The following is a description of a gene set: The activation signaling of transcription factor nuclear factor-kB (NF-kB) plays central role for immune system. One of key kinase mediating this pathway is TAK1 in adaptive and innate immunity. However, role of TAK1 in B cell receptor signaling is still unclear. To know effects of TAK1-deletion on the gene expression induced by anti-IgM, we performed the time course analysis in comparison of wild type with TAK1-deleted splenic B cells. from publication Shinohara H, Behar M, Inoue K, Hiroshima M, Yasuda T, Nagashima T, Kimura S, Sanjo H, Maeda S, Yumoto N, Ki S, Akira S, Sako Y, Hoffmann A, Kurosaki T, Okada-Hatakeyama M (PMID 24833394) Human Gene Set: GSE41176_UNSTIM_VS_ANTI_IGM_STIM_TAK1_KO_BCELL_3H_UP studied in species Homo sapiens Genes up-regulated in B lymphocytes with MAP3K7 knockout: untreated versus anti IgM for 3h., and this is the list of marker genes: RAMP2, TRIM11, TMEM238, CDHR1, GGNBP2, CARM1, FGF17, DCAF4, ZFP41, MRPL46, ELMOD3, RERG, PSMG1, LINC00612 (NCBI Gene Id 442755), PYCR3, ZNF629, BORCS7, ECH1, RAB3GAP1, PGAP4, DKK1, LYZL1, STOX1, ADORA2A (adenosine A2a receptor), MISP, SMIM20, ATP7B, TBC1D16, LRRIQ4, HCRTR1, POLR2E, KLHL23, INSYN1, CYTH3, SLX9, CEP131, SLC22A9, RPL35, COMMD7, GLIS3, FBXL14, SLC15A4, MBOAT4, SLC4A10, IL24, CCDC146, EHMT2, CFD, WIF1, KY, DDI1, SH2D5, SNRNP27, XPNPEP3, PRR14L, CLK3, C1QTNF12, ZIC5, FANCD2OS, CCDC73, DUS2, SEMA3D, NUDT18, KRTDAP, OPALIN, KCTD2, SMCO4, AEBP1, KPTN, CYP17A1, TRMT44, SAP30L, MGAT3, SRRD, LAMTOR4, ALKBH3, INSRR, ADAM22, PGP, SLC35D3, SLC25A6, DNALI1, BOLA3, HOXC8, SLC26A1, IFT140, ELOF1, CLTB, DOCK6, RAD9B, ALDH3B1, ARRDC4, TNNT3, TTBK2, GPS2, CGN, ASCC1, GRIK2, SLC25A14, TSPAN1 (tetraspanin 1), POM121L12, CEND1, DLK1, KLHL36, GPRIN2, ELAVL3, SH2D3C, TNRC6A, KCNC4, FXYD5, MED12L, EDA, SAP18, TMEM39B, LMOD3, CPLANE1, LVRN, C9orf50, ARHGEF10L, CFDP1, REG3A, LHB (luteinizing hormone subunit beta), BTC, MEAF6, MYRFL, NPAS1, FAM13C, RAI1, NTN1, TSLP, MIF, RPP21, DPF1, DPPA5, NUPR2, MRPS18A, ZFR (zinc finger RNA binding protein), SMAD5, NPM3, KRT35, MYCL, C10orf62, LIMD1, GOLT1A, HSD17B6, OPA3, MED12, ALG5, KLKB1, TSHZ2, MARF1, FAM181A, PLAAT1, GML, SKOR1, LRRC20 (NCBI Gene Id 55242), TRIM63, PI15, MACROD2, CORIN, APBA1, ARSK, BTK, RSPH1, ILK, ZFP42, HMX1, DAPK3, EIF3G, C1orf53, PEBP1, UPF3A, SLC24A4, PRF1, FHDC1, SYNE2, PARD6G, RIC8B, NEUROD1, SOST, POLDIP2, IL17RB, MAB21L3, CYP4A11, LRRC39, CCDC30, REC114, ME3, SLC35F3, TACSTD2, SGSM3, NOS2, STXBP1, PFN2, ABCA6, KRTAP3-3, RASAL2, GUCY1B1